The following is a description of a gene set: species: Homo sapiens Genes predicted to be targets of miRBase v22 microRNA hsa-miR-4760-5p in miRDB v6.0 with MirTarget v4 prediction scores > 80 (high confidence targets). from publication Chen Y, Wang X (PMID 31504780) Human Gene Set: MIR4760_5P, and this is the list of marker genes: IMPG2 (interphotoreceptor matrix proteoglycan 2), RFPL1, COPS3, ATR, CTNND1, PARG, GK5, CCDC138, TM4SF18, PTPN21, ENPEP, KCNQ5, PITRM1, SPRED1, ELOVL5, FBXL17, CCDC88A, ANOS1, SLC25A46, ZNF99, VPS72, KRT38, SH3TC2, FNDC3B, SLFN11 (schlafen family member 11), GMCL1, ZNF267, CDC34, KNSTRN, NBEA, ABHD5, POC1B-GALNT4, MTERF1, LGSN, TMEM263 (transmembrane protein 263), KAZN, FXYD3 (FXYD domain containing ion transport regulator 3), DLK1, ZFYVE16, GALNT4, AMD1, RAB3C (RAB3C, member RAS oncogene family), LATS1, NPEPPS, RNF6, SEPHS2, AASDH, YME1L1, ADGRL3, PEX5L, KCNMA1, NGLY1, CCNY, NMU, LGR4, GABRG2, SLC28A3, FMO3 (NCBI Gene Id 2328), HCN1, TJP1, MDH1, KCNA4, FAM210B, ZNF148, PPP1R15B, ACSS3, ELAVL4, MFSD14A, PSD3, LAMA4, PATL2 (PAT1 homolog 2), ASNS, LHFPL2, FGD6, TENT4B, YES1, USH2A, MOB1B, UBAP1, LEP, PRL, VCAN, PMP22, CISD1, C1orf141, SLC4A7, THAP12, IFNG, PABPC3 (poly(A) binding protein cytoplasmic 3), NFIB, PTHLH, RDX, KRT222, DFFA, TMEM229A (transmembrane protein 229A), ZFP91, XRN1, NR3C2, ABCG2, GOPC, NBR1, ACOX1, MRRF, ZNF704, MAP3K20, KCNJ16, UBE2G2, STAU1, ZMYM5, BPNT2, HACD4, SOX11, RNF217, AKAP12, PTAR1 (protein prenyltransferase alpha subunit repeat containing 1), CYYR1, ARID2, EMB (NCBI Gene Id 133418), LRRC31, ARHGAP5, LRRC4C, UNC80, MINDY2, HS3ST1, TRHDE, HADHB, HCFC1, TOR1AIP2, TTC21B (tetratricopeptide repeat domain 21B), STC2, FAM13C, SUSD5, FSD2, PI15, NTS, PID1, IFT57 (intraflagellar transport 57), ETV1, CD44 (NCBI Gene Id 960), CWC15, TMEM33 (transmembrane protein 33), SLITRK4, FUT9, MBNL2, MSL3, RAB27B, ZBTB20, PPP4R2, RBM18, EGLN1, GOLGA3, CYBRD1, FKBP7, SCP2, C2orf66, HNRNPLL, SLC1A1, NEK7, TUSC1, DEK, KCND2, PEX1, RSBN1, CCNT2, SEMA3A, MARCHF1, RHOU, DENND1B, CFHR5, ARL5B, POLI, NTNG1, MKRN1, DIS3, CCL7, KIF2A, ZNF333 (zinc finger protein 333), ZDHHC20, NRN1, CHUK, MAP4, NUDT15, KIF5C, RIOK2, DELEC1, WDR17, CAPN14, PIK3CA, TNKS2, PABPC4L, APOOL, CLIP4, PPM1K, PCDH7 (NCBI Gene Id 90855), GLDN